Given this list of marker genes Coro2a, Trim30d, Ifitm2, Bhlhe40, Pkib, Ifi207, Edem1, H2-T23, Psma4, Txndc17, Samhd1, Prdx1, Jtb, Fbxw17, Pdcd10, Sec23b, Armcx3, Plgrkt, Isg20, Sp110, Timm10b, Cdkn1a, Cct3, Il4ra, Larp1, Casp4, Bcl3, Tle3, Nrbp1, Srgn, H2az1, Ifi35, Phb1, Csrp1, Ifi204, Dnase1l3, Bcl2a1a (B cell leukemia/lymphoma 2 related protein A1a), Oasl2, Ppp1r2, Eif6, Ggta1, Sdhd, Cdk2ap2, Rab8b, Irf7, Riok3, Ctss, Lgals9, Bcl2l11, Ifi209, Cpne2, Larp1b, Usp25, Ms4a6d, Ldha, Slfn2, Etv3, Orai1, Ifi211, Foxp4, Snx6, Sh3glb1, Apol7c, Snap23, Sct, Psma3, Csrnp1 (NCBI Gene Id 215418), Cdc42se1, Cyrib, Lmnb1, Prpf18, Chd7 (NCBI Gene Id 57137), Pdcd1lg2, Kynu, Cxcl9 (C-X-C motif chemokine ligand 9), Flot1, Acadl, Tes, Cmtm6, Ccdc86, Slc35b1, Bbx, Nudt16l1, Clic4, Irf5, Irgm1, Gadd45g, Ifi47, Lgmn, Flnb, Slco3a1, Lgals3bp, Prpf38a, Fnbp1l, Cox17, Il18 (NCBI Gene Id 16173), Apobec3, Stat2, Ier3, Ly6a, Il1b, Btla, Eif2ak2, Tmem131l, Plscr1, Atp6v1g1, Socs3, Auh, Glipr2, Csf2rb, Tbc1d8, Mkrn1, Myd88, Wfdc17, Trafd1, Parp14, Tmbim6, Scimp, Smagp, Nlrc5, Tbcb, Scand1, Ciao2b, Marcks, Itgae, Slc25a38, Zc3hav1, Nampt, Snn, Ccnd2, Spi1, Xaf1, Rab10, Chmp4b, Ms4a6c, Lrrk1, Rac1 (Rac family small GTPase 1), Rnf213, Ifi205 (NCBI Gene Id 226695), Necap2, Eva1b, Cd300a, Marchf5, Arf4, Trim30a, Jak2, B2m, Etv6, Syngr2, Psenen, Sri (sorcin), Hnrnph2, Baz1a, Arhgap22, Pik3r5, Ewsr1, Zbp1, Cd38, Mif4gd, Fdps, Eif1, Gbp2, Calm1, Tubb4b, Ly6e, Dek, Zfp800, Pfkp, Gadd45b, Gatm, Slfn5 (schlafen 5), Atp6v1a, Bin2, Reep5, Mab21l3, Pfn1, Stat1, Isg15, Mtss1, Zyx, Morf4l1 (mortality factor 4 like 1), Cxcl16 (C-X-C motif chemokine ligand 16), Dnaja2, Cd40, Cacnb3, Pdk3, Heatr6, Kmo, Ube2d2a, Frmd4a, Sumo2, Ass1, Nsd3, Mvp, Litaf, Bcl2l14, Dusp2, Oasl1, Scfd1, Sinhcaf, Dynlt1f, Spop, Sp100, Ifitm3, Irf1, Fgr, Bcl2a1b, Gyg1, Fbxo6, Bcl2a1d, Atp6v1d, Abhd16a, Ccnd3, Ncbp3, Pim1, Nras, Naa20, Dhx58, Mbd2, Tpm3, Fabp5, Socs1, Stip1, Tpm4, Ndrg1, Traf1, Gnb4, Cycs, Phf11d, Lamp2, Zfand3, Tuba1b (NCBI Gene Id 22143), Cd53, Nmi, Cst3 (cystatin C), Psme2, Crem, Tor1aip2, Eif5a (eukaryotic translation initiation factor 5A), Basp1, Adam8, Sdc4, Trpc4ap, Tspo, Ptpn1 (protein tyrosine phosphatase, non-receptor type 1), Ikzf2, Anxa7, Cd274, Usp18, Cldnd1, Laptm4b, Ube2l6, Tax1bp1, Ogfr, Rbx1, Stxbp3, Atp8a1, Plek, Man1a, Pnp, Casp8, Tmem131, Adam19, Akr1a1 (NCBI Gene Id 80456), Clec2d, Cflar, Hnrnpa3, Gbp5, Laptm4a, Herc6, Mt1, Serpina3g, Ppa1, Snx8, Fam241a, Ms4a4c, here is a description of the gene set: Cytokines mediate cell-cell communication in the immune system and represent important therapeutic targets. A myriad of studies have highlighted their central role in immune function, yet we lack a global view of the cellular responses of each immune cell type to each cytokine. To address this gap, the authors created the Immune Dictionary, a compendium of single-cell transcriptomic profiles of more than 17 immune cell types in response to each of 86 cytokines (>1,400 cytokine-cell type combinations) in mouse lymph nodes in vivo. A cytokine-centric view of the dictionary revealed that most cytokines induce highly cell-type-specific responses. For example, the inflammatory cytokine interleukin-1β induces distinct gene programmes in almost every cell type. A cell-type-centric view of the dictionary identified more than 66 cytokine-driven cellular polarization states across immune cell types, including previously uncharacterized states such as an interleukin-18-induced polyfunctional natural killer cell state. Mouse Gene Set: CUI_CDC1_IL36A_RESPONSE_UP Genes positively differentially expressed in cell type: cDC1 (conventional dendritic cell type 1) upon treatment with cytokine: IL-36α in mouse lymph nodes in vivo. from publication Cui A, Huang T, Li S, Ma A, Pérez JL, Sander C, Keskin DB, Wu CJ, Fraenkel E, Hacohen N (PMID 38057668) species: Mus musculus